Given this list of marker genes Tigar, Casp3, Serpinf1, Atf1, Alad, Bnip3, D2hgdh, Casp9, here is a description of the gene set: studied in species Mus musculus Any process that results in a change in state or activity of a cell or an organism (in terms of movement, secretion, enzyme production, gene expression, etc.) as a result of a cobalt ion (Co2+) stimulus. Mouse Gene Set: GOBP_RESPONSE_TO_COBALT_ION